Given this list of marker genes Svep1, Angpt1, Angpt2, Tek, Angpt4, here is a description of the gene set: Mouse Gene Set: GOBP_TIE_SIGNALING_PATHWAY The series of molecular signals initiated by an angiopoietin binding to the Tie receptor, and ending with the regulation of a downstream cellular process, e.g. transcription. species: Mus musculus